The following is a description of a gene set: A pituitary functional deficit affecting all the anterior pituitary hormones (growth hormone, thyroid-stimulating hormone, follicle-stimulating hormone, luteinizing hormone, adrenocorticotropic hormone, and prolactin). species: Homo sapiens Human Gene Set: HP_PANHYPOPITUITARISM Panhypopituitarism, and this is the list of marker genes: POU1F1, PROP1, TGIF1, SMC1A, PLCH1, FGF8, FGFR1, DLL1, RNF113A, STIL, GLI3, SIX3, LHX3, PTCH1, GAS1, SOX3, DISP1, CDON, KATNIP, HESX1, ZIC2, SUFU, LHX4, CRIPTO, GLI2, MADD, NODAL, FOXH1, SHH, STAG2, GRM7